Given this list of marker genes FOXP1, HOXA9, BMPER, TGFBR1, P2RX4, TCIM, MIR92A1, SMAD4, PPIA, PRMT5, CXCL10, here is a description of the gene set: The change in morphology and behavior of an endothelial cell resulting from exposure to a cytokine, chemokine, cellular ligand, or soluble factor. Human Gene Set: GOBP_ENDOTHELIAL_CELL_ACTIVATION studied in species Homo sapiens